Given this list of marker genes LRPPRC, SLIRP, GRSF1, SUPV3L1, PNPT1 (polyribonucleotide nucleotidyltransferase 1), here is a description of the gene set: Any process that modulates the frequency, rate or extent of the chemical reactions and pathways involving catabolism in the mitochondrion of RNA transcribed from the mitochondrial genome. Human Gene Set: GOBP_REGULATION_OF_MITOCHONDRIAL_RNA_CATABOLIC_PROCESS studied in species Homo sapiens